The following is a description of a gene set: Human Gene Set: MODULE_439 species: Homo sapiens Genes in the cancer module 439., and this is the list of marker genes: MT1G, DNAJC3, VIPR1, PCNA, BCL2A1, CD2, MYBL2, BIRC5, G0S2, IER3, CDK4, EREG, NFKB1, GET1, PLK1, LAP3, RNASE3, CDC45, LRRN3, ANXA7, CCNB1